Given this list of marker genes NXT2, C8orf33, DZANK1, PEX1, CENPK, METTL25 (NCBI Gene Id 84190), TRIAP1, GATB, PIGT, SUMF1, CTSA, PPWD1, NDOR1, SFSWAP, MIR638, ZNF830, IDH3B, TOP3A, SMCR8, UBE3B, COPS7B, MED6, RBM42 (NCBI Gene Id 79171), GNPTG, SPNS1, NAGPA, CCDC59, IDH3B-DT, VPS50, SUPT7L, PER2, SMG8, EIF2D, METTL15, KCTD10, LMF2, ZC3HC1, EVI5L, GTF3C5, PDE6D, CWF19L1 (CWF19 like cell cycle control factor 1), RBM48, GATC, RRP15, TSR3, ALG1, POLR3F, TMEM203, GET3, CCT6B, NEURL2, NCAPH2, DNM2, DDX55, GPATCH3 (NCBI Gene Id 63906), PER1, SLC4A1AP, NLK, here is a description of the gene set: Genes containing one or more binding sites for (YBX3) in their promoter regions (TSS -1000,+100 bp) as identified by GTRD version 20.06 ChIP-seq harmonization. Human Gene Set: YBX3_TARGET_GENES species: Homo sapiens from publication Yevshin I, Sharipov R, Kolmykov S, Kondrakhin Y, Kolpakov F (PMID 30445619)